Given this list of marker genes H6pd, Chfr, Fam171a1, Tigd2, Rab10, Prepl, Zcchc18, Otud7a, Aak1, Tcl1b5, Ktn1, Xk, Psg29, Cyp46a1 (cytochrome P450, family 46, subfamily a, polypeptide 1), Rac1, Zmynd19, Zfp790, Fam107b, Dcaf10 (NCBI Gene Id 242418), Dnm3, Tram1, Klf6, Nfasc, Stx6, Wipf1, Paqr6, Slc26a3, Prkcd, Dlx5, Tbc1d17, Cebpz, Cxadr (coxsackie virus and adenovirus receptor), Tcl1b4, Mrps36 (NCBI Gene Id 66128), Jak2, Bgn, Ago4, Nudt13, Shc1, Fam91a1, Exd2, Dixdc1, Nrf1, Ctps2, Usp36, Dcun1d3, H2-T15, Cd33 (CD33 molecule, NCBI Gene Id 12489), Ccdc171, Tcl1b3, Yy1, Elavl3, Anxa4, Rap1b, Chil3, Antxr2, Esr1, Mep1a, Pik3r3 (NCBI Gene Id 99994), Mapk10, Ap3s1, Cpa3, Pgm5 (phosphoglucomutase 5), Egfl6, here is a description of the gene set: Genes predicted to be targets of miRBase v22 microRNA mmu_miR_3105_5p in miRDB v6.0 with MirTarget v4 prediction scores > 80 (high confidence targets). studied in species Mus musculus Mouse Gene Set: MIR_3105_5P from publication Chen Y, Wang X (PMID 31504780)